Given this list of marker genes Gpx1, Dusp1, Srrm2, Tspan3, Hspa1b, Rptor, Tnfaip2, Sec11c, Rassf4, Pbxip1, Cbfa2t3, Clu, Kctd12, Atp2b1, Synpo2, Malt1, Swap70, Ccdc88a, Ccl22, Colgalt1, Id2, Ftl1, Btg2, Zbtb46, Rcsd1, Ankhd1, Mt1, Mknk2, Nrp2, Ankrd33b, Itgb8, here is a description of the gene set: Cytokines mediate cell-cell communication in the immune system and represent important therapeutic targets. A myriad of studies have highlighted their central role in immune function, yet we lack a global view of the cellular responses of each immune cell type to each cytokine. To address this gap, the authors created the Immune Dictionary, a compendium of single-cell transcriptomic profiles of more than 17 immune cell types in response to each of 86 cytokines (>1,400 cytokine-cell type combinations) in mouse lymph nodes in vivo. A cytokine-centric view of the dictionary revealed that most cytokines induce highly cell-type-specific responses. For example, the inflammatory cytokine interleukin-1β induces distinct gene programmes in almost every cell type. A cell-type-centric view of the dictionary identified more than 66 cytokine-driven cellular polarization states across immune cell types, including previously uncharacterized states such as an interleukin-18-induced polyfunctional natural killer cell state. from publication Cui A, Huang T, Li S, Ma A, Pérez JL, Sander C, Keskin DB, Wu CJ, Fraenkel E, Hacohen N (PMID 38057668) Mouse Gene Set: CUI_MIGDC_IFNB_RESPONSE_DN Genes negatively differentially expressed in cell type: MigDC (migratory dendritic cell) upon treatment with cytokine: IFN-β in mouse lymph nodes in vivo. species: Mus musculus